Given this list of marker genes Hspb1, Cnih2, Bloc1s1, Snapin, Kif5b, Kif1b, Ap3m2, Kif21a, Spg7, Spast, Mgarp, Dlg2 (discs large MAGUK scaffold protein 2), Map2, Nefl, Ap3m1, Arl8a, Neto1, Bloc1s3, Ap3d1, Fez1, Trim46, Sod1, Borcs5, Rab27b, Bloc1s4, Kif5a, Ap3b2, Bloc1s6, Agbl4, Ank3, Map1a, Hap1, Agtpbp1, Caly, Mapk8ip3, Bloc1s2, Sybu, Kif3a, Rab21, Kif1a, Ap3s1, Madd, Dtnbp1, Kif5c, Kif1c, Ap3s2, Bloc1s5, Arl8b, Ap3b1, Mecp2, here is a description of the gene set: Mouse Gene Set: GOBP_ANTEROGRADE_AXONAL_TRANSPORT The directed movement of organelles or molecules along microtubules from the cell body toward the cell periphery in nerve cell axons. species: Mus musculus